Given this list of marker genes Xlr5b, Iho1, Slx, Gm6421, H3f5, Smc1a, Rnf212b, Gm28919 (NCBI Gene Id 102633564), Hus1, Tex11, Gm29866, Syce1 (synaptonemal complex central element protein 1), 3830403N18Rik, Gm20843, Topbp1, Hus1b, Stag3, Gm21760, Polb, Gm28102, Msh5, Ago3 (argonaute RISC catalytic subunit 3), Nat8, Xlr5a, Gm28870, Kash5, Rad9a, Kifap3, Rad9b, Smc1b, H3f4, Xlr3a, Gm20820, Xlr, H3f3a-ps1, Xlr4a (X-linked lymphocyte-regulated 4A), Smc2, Gm773, Mlh1, Fkbp6, Gm10257, Gm7958, Ncaph2, Hormad2, H1f6, Rad1, Tex12, Xlr3b, Xlr5c, H3f3c, Gm21865, Brca2, Gm21095, Rsph1, Rpa1, Smc3, Gm4297, Gm29554, Lig3, P3h4, Gm1140, Gm6121, Dmc1, Gm5934, Mei4, 4930447C04Rik, Sycp2l (NCBI Gene Id 637277), Syn1, Gm2030, Hmg20b, Nol6, Smc4, Xlr4c, Rnf212, Syce1l, Gm5169, Msh4, Tubg1, Gm21627, Gm20817, Rad21l, Gm28510, Gm21294, Gm20870, Gm21996, Syce3, Ncapd3, Rad51, Rcc1, Ttn, H3f3a-ps2 (H3.3 histone A, pseudogene 2), Shoc1, H2ax, Syce2, Gm28961, Gm5935, Gm14525, Lrpprc, Psmc3ip, Mlh3, Hormad1, Rec8, Gm1993, Ncapg2, Xlr3c, 1700013H16Rik, Chmp1a, Rrs1, Gm10230, Nifk, Nek2, Hspa2, Gm20736, Ncaph, Ccnb1ip1, Sun2, Blm, Chek1, Brca1, Gm21858, Gm20824, Sycp1, Ncapd2, Add3, Gm29276, Mre11a, Plk1, Gm10488, Xlr4b, Sycp2, Atf6b, Gm28576, Gm20890, Rad21, Incenp, Slxl1, Gm21117, Gm20911, Sycp3, Cdx2, Rad50, Brd4, Gm2012, Gm5168, Dnmt3l, here is a description of the gene set: Mouse Gene Set: GOCC_CONDENSED_NUCLEAR_CHROMOSOME A highly compacted molecule of DNA and associated proteins resulting in a cytologically distinct nuclear chromosome. studied in species Mus musculus